The following is a description of a gene set: Catalysis of the reaction: phosphatidylcholine + a sterol = a sterol ester + 1-acylglycerophosphocholine. Human Gene Set: GOMF_PHOSPHATIDYLCHOLINE_STEROL_O_ACYLTRANSFERASE_ACTIVITY studied in species Homo sapiens, and this is the list of marker genes: APOA1, APOA4, LCAT, APOE, APOC1, APOA5, APOA2